The following is a description of a gene set: Genes predicted to be targets of miRBase v22 microRNA mmu_miR_7227_3p in miRDB v6.0 with MirTarget v4 prediction scores > 80 (high confidence targets). from publication Chen Y, Wang X (PMID 31504780) Mouse Gene Set: MIR_7227_3P species: Mus musculus, and this is the list of marker genes: L2hgdh, Sgpl1, Gucy1a2, Sema3e, Mybl1, Ccnt2, Eml5, Tigd4, Kctd1, Dzip3, Cnr1, Mid2, Asxl3, Edc3, Ubn2, Pcm1, Gng2, Atp11c, Tmem41b, Zdhhc20, Nsf, Hectd2 (HECT domain E3 ubiquitin protein ligase 2), Kif5b, Fam81a, Grm1, Zfp1009, Pkig, Sfxn1, Cggbp1, Golgb1, Sema5a, Rbms3, Zfp967, Nhlh2, Ubxn7, Ino80d, Atrx, Mindy3, Gab3, Washc4, Rab1a, Sema3a, Hesx1, Sptlc2, Rab10, Slc24a2, Nadk, Kras, Arid4a, Braf, Lmo3, Hmgcs1, Aasdhppt, Yod1, Grin1os, Metap2, Atm (ataxia telangiectasia mutated, NCBI Gene Id 77416), Mss51, Mbtd1, Top1 (topoisomerase (DNA) I), Ube2h, Celsr2, Pcdha1, Ids, Fat3, Zbtb44, Hoatz, Tbc1d12, Ccdc85a, Sgip1, Sdhd, Akap13, Cdk17, Thrb, Vcpip1, Slco1a6, Ubxn2b, Dnajc10 (NCBI Gene Id 66861), Zfp971, Pcdha3, Ywhae, Ranbp17 (RAN binding protein 17), Tmem184b, Sbf2, Ptprb, G6pc2, Taf1b, Qser1, Bbx, Eef2, Rarres1, Cyp7a1, Pik3cg, Dcun1d5, Usp37, Socs7, Or52n4, Cebpzos, Rnft1, Ptprj, C2cd5, Taf4, Pcdha6, Dpy19l3, Pex3, Mbd4, Tmc7, Plxdc2, Tmtc3, Smg1, Ralgps2, Chrdl1, Lyrm1, Zfp398, Klhl24, Tiparp, Elp4 (NCBI Gene Id 77766), Map9, Tmem59, Btbd18, Ret, Hacd2, Adamts5, Dlg1 (NCBI Gene Id 320792), Nfat5, Zfp827, Itm2c, Arl15, St6gal1, Agap1, Med14, Srgap1, Bnc2, Lrch2 (NCBI Gene Id 278230), Pou3f1, Adamts19, Igsf9b, Rwdd1, Elavl1, Bcl2l2, Kpna4, Rab3gap2, Tgfa, Taf7, Nqo2, S2bpcox16 (NCBI Gene Id 105940408), Rab8b, Sumf1, Nebl, Rxra, Hgf, Bmpr2, Map3k2, Adam12, Cpeb2, Meioc, Rubcnl, Bicd1, Thsd7a, Zfp706 (zinc finger protein 706), Tardbp, Ssx2ip, Nab2, Ostc, Esyt2, Arhgap29, Rhoq, Slc38a7, Eloc, Car8, Serbp1, Larp4b, Usf3, Rabep1, Aak1, Donson, Cert1, Vma21, Itga6, Stambpl1, Ptpn21, Il17a, G3bp1, Arfgef2, Aicda, Paxbp1, Ssr1, Sumo1, Kndc1 (kinase non-catalytic C-lobe domain (KIND) containing 1), Hnrnpa0, Ttpa, Pcdhac1, Ski, Pcdha10, Stxbp6, Nab1, Pou3f3, Klc2, Ikzf2, Col19a1, Mmd, Naip1, Kcnc2, Mgat4a, Ebf3, Zfp507, Brd10, Rimbp2, Hccs, Csmd3, Ipo8, Nkain2, Cd44, Chd9, Cstb (NCBI Gene Id 13014), Men1, Pcdha7, Aebp2, Ddx3x, Man1c1, Icos (inducible T cell co-stimulator), Dido1, Tmed10, Zmym6, Krtap8-1, Zfp966, Onecut2 (one cut domain, family member 2), Ppp1r9a, Spin2c, Avl9, Ammecr1, Cnot6, Sfxn4, Dcx, Lrp8, Snx1, Map2k2 (mitogen-activated protein kinase kinase 2), Prkag2, Tfap2c, Micu3, Ppm1b, Vps37a, Zfp652, Pcdha5, Pou4f2, Rb1cc1, Dcun1d4, Ppm1g, Asah1, Rapgef4, 4921524J17Rik, Slk, Npr3, Nom1, Tnrc6c, Kdm7a, Slitrk1, Rnd1, Creb5, Tspan2, Tram1l1, Spast, Hook3, Glcci1, Pcdhac2, Dnmt3a, Epha5, Ercc4, Fem1c, Vcan, Kctd12, Dennd10 (NCBI Gene Id 67894), Carnmt1, Reck (reversion-inducing-cysteine-rich protein with kazal motifs), Plekha8, Zmynd11, Pcdha11, Fuca2, Gria3, Mex3c, Mef2c (NCBI Gene Id 71350), Carf, Fzd3, Kcnd2, Elf1, Cep41, Spag16, Arhgap6, Tmem132b, Septin8, Pds5b, Ptbp3, Prrt4, Wdfy3, Zwilch, N4bp2l2, Ythdf2, Arl8b, Dcc, Yes1, Rab3c, Rnf138, Dgkb, Inpp4b, Ggcx, Sspn, Rfx3 (regulatory factor X, 3 (influences HLA class II expression)), Trak2, Gabbr1, Mapk9, Tmem107, Pdha2, Moxd1, Slc25a31, Scai, Mical2, Kbtbd8 (kelch repeat and BTB (POZ) domain containing 8), Dcstamp, Ddx46, Spty2d1, Btla, Rbm44, Ptchd1, Pcdha9 (protocadherin alpha 9), Rasa1, Rabgap1l, Mcidas, Tyr (tyrosinase), Dixdc1, Agpat5, Rbm24, Trps1, Mmut, Gak, Mixl1, Ubr2, Rheb, Appbp2, Pak2, Slc6a1, Thoc2, Acvr1, Phip, Srp54a, Nr2c2, Chrd, Cep170, Or51ab3, Pcdh7 (protocadherin 7), Foxd1, Bmpr1a, Abhd13 (NCBI Gene Id 68904), Cdh2, Spred1, Ash1l, Resf1, Nr3c1 (nuclear receptor subfamily 3, group C, member 1), Trim36, Myl12a, Irag1, Chd5, Ralgps1, Yipf4, Nubpl, Hycc2, Unc5d, Nalcn, Wdr1, Mapk8, Cacul1, Pm20d2, Wnk3, Dlx2 (NCBI Gene Id 99330), Csmd2, Gdpd1, Sec14l1, Pias1, Zbtb7c, Ppp4r2, Zfp111, Gja5, Naaladl2, Nell2, Frk, Psmd12, Hlf, Pam, Rsf1, Bcl10, Zfp148, Il17rd, Stag2, Plk3, Rnf214, Cog7, F11, Zfp639, Bend3, Ect2, Slc30a4, Golga4, Rtf1, Cldn12, Sestd1, Adamtsl3, Pde1c, Rundc3b, Nlgn1, Glra2, Nup160, Cox16, Psma3, Cetn4, Hmgn5, Kalrn, Zdhhc21, Papolg, Pcdha2, Sav1, Phtf2, Slc39a8, Yme1l1, Atp8a1, Rnf41, Adam22, Pcdha12 (protocadherin alpha 12), Hnrnpr, H2bw2, Atp6v0a2, Tsn, Lats1, Crebzf, Zmat3, Actn1, Tob2, Tra2b (transformer 2 beta), Zfp39, Golm2, Mier1, Smco3, Bbs5, Hjurp, Edar, Ttc39b, Usp32, Rab18, Cdyl2 (chromodomain protein, Y chromosome-like 2), Cpeb3, Eny2, Mapk1ip1l, Tmem8b, Klf12, Msrb3, Vsig1, Oat (ornithine aminotransferase), Tmed7, Cand1, Usp15, Fut9, Ppig, Phlda1 (pleckstrin homology like domain, family A, member 1), Tmco3, Rprd1a, Rab33b, Med1, Atxn7, Sgms2, Pcdha4, Lancl3, Trhde, Eif2ak3, Pde5a, Psd3, 9330159F19Rik, Crebrf, Dpp4, Cwc27